Given this list of marker genes HSP90AA1, PPP1R3G, STAU1, SIGLEC11, SH2D4A, HSP90B1, EGFR, CEACAM1, NHERF2, ELL, STYXL1, GNA12, ANKLE2, DYNLT4, ADISSP, NHERF1, SOD1, PPP1R3C, MAPK3, CSRNP2, KCNQ1, PPP1R18, CNST, CDH2, PPP1R3B, PPP6R3, IGBP1C, SPTBN4, AKAP5, TSC2, AP3B1, CARHSP1, PVRIG, PPP1R15A, SAXO4, CTNND1, RCAN3, PPP1R3F, EIF2AK3, TRAF2, CRY1, DLG4 (discs large MAGUK scaffold protein 4), ENSA, PPP1R35, SIRPA, ATP2B4, SH3YL1, FCRL6, CD33, SBF2, ANK1, SH3RF2, WNK1, STRN3, SKAP1, SPHK1, SMG7, BOD1, AKAP11, IRS2, MAPK8, IKBKE, CEP192, PPP1R3D, CTSC, LGALS3, MASTL, ANAPC4, DAB2IP, PPP1R11, YWHAZ, SYK, PPP1R10, SLC6A3, SFI1, MFHAS1, MAPK1, PPP6R2, PPP2R2A, SNX3, PTPA, PTK2, KCNN4, LILRB2, KIF3A, GHR, SMG5, SYTL2, MAPT, IQGAP1, GIT1, CTTNBP2NL, PPP6R1, ARPP19, PPP3CB, JAK1, CD22, STX17, TRPC4AP, MAP2K7, STRN4, MAPK14, SMAD3, MTMR3, STAT1, CHCHD3, MET, ANAPC5, PHACTR4, CACNG8, TP53, PXN, KAT2A, LCK, FBXL2, BAD, TRAF3, PDLIM4, PPP3R2, LILRB4, FER, CSK, SLC9A1 (solute carrier family 9 member A1), GTF2F1, CDH5, JAK3, HSF4, AMBRA1, CDKN1B, CLEC12B, VCP (valosin containing protein), PPP3R1, PPP1R27, SPRED1, VRK3, PPME1, STAT6, ROS1, SMAD2 (NCBI Gene Id 654050), PPP1CC, PPP1R3E, PIK3R2, ANAPC7, STAT3, PPP1R36 (NCBI Gene Id 145376), YWHAE, MARK3, NFATC2, TPRN, NFATC1, PPP1R9B, CRY2, PTPRT, FCRL2, TERF2IP, IGBP1, MYO16, MAGI2, CFL1, MYOZ2, BCL2, FCRL3, DLG3, PPP1CA, PABIR1, MTMR4, RPA2, NEK2, CADM4, PPARA, MAST2, JUP, PIK3R1, CDC27 (NCBI Gene Id 996), FOXO1, KIFAP3, PTPN1, LILRB1, RACK1, DZIP3, CTNNB1, GRB2, STRN (striatin), PPP1R3A (NCBI Gene Id 5506), TBK1, SHOC2, ADCY8, FLT4, MAP3K5, DLG1, SIGLEC10, ITGA1, MVP, MTMR9, GRIN3A, CSF1R, SMTNL1, here is a description of the gene set: Binding to a phosphatase. studied in species Homo sapiens Human Gene Set: GOMF_PHOSPHATASE_BINDING